Given this list of marker genes MSMP, CCR2, DEFB106A, CCL2, CCL7, DEFB106B, here is a description of the gene set: species: Homo sapiens Binding to a CCR2 chemokine receptor. Human Gene Set: GOMF_CCR2_CHEMOKINE_RECEPTOR_BINDING